The following is a description of a gene set: Genes regulated in the opposite directions by v-MYB (UP) and c-MYB (DN) variants of CMYB overexpressed in primary monocyte cultures off adenoviral vectors. The v-Myb oncoprotein encoded by Avian Myeloblastosis Virus is highly oncogenic, induces leukemias in chickens and mice and transforms immature hematopoietic cells in vitro. The v-Myb protein is a mutated and truncated version of c-Myb, a DNA-binding transcription factor expressed in many cell types that is essential for normal hematopoiesis. Previous studies suggested that two types of differences, DNA binding domain mutations and the deletion of a C-terminal negative regulatory domain were important for increasing the transforming activity of v-Myb. Here, we combined structure-function studies of the v-Myb and c-Myb proteins with unbiased microarray-based transcription assays to compare the transcriptional specificities of the two proteins. In human cells, the v-Myb and c-Myb proteins displayed strikingly different activities and regulated overlapping, but largely distinct sets of target genes. Each type of mutation that distinguished v-Myb from c-Myb, including the N- and C-terminal deletions, DNA binding domain changes and mutations in the transcriptional activation domain, affected different sets of target genes and contributed to the different activities of c-Myb and v-Myb. The results suggest that v-Myb is not just a de-repressed version of c-Myb. Instead, it is a distinct transcriptional regulator with a unique set of activities. from publication Liu F, Lei W, O'Rourke JP, Ness SA (PMID 16205643) studied in species Homo sapiens Human Gene Set: LIU_TARGETS_OF_VMYB_VS_CMYB_UP, and this is the list of marker genes: AGXT2, C20orf203, FGL2, NAXE, ZNF385D, CASQ1, LIPA, CNBD1, IL18BP, FAM210A, SBSPON, CD109, RAB11FIP3, MYOM3, WLS, PPP1R14D